Given this list of marker genes HMGB3P30, SF3B2, PTPN2, KRT7, ATP2B4, BIRC2, FOXB1, TRBC1, TCL1A, GCC1 (GRIP and coiled-coil domain containing 1), ZNF177 (zinc finger protein 177), WDR33, VAV3, PMS2P2, TRANK1, TUG1, CTDSP2, KDM7A, TMEM80, PTPRC, TRAPPC2, ING3, NAA38, NDRG1, CASP4 (NCBI Gene Id 837), RPS6, BACH1, PADI1, CDHR1, CNTRL, S100P, PITX3, ADAR, HEXIM1, MAP1LC3B, SULT1B1, USP15, GABPB1-IT1, MAPK14, THAP11, REPS2, TLL2, TUBD1, PHF1 (PHD finger protein 1), HBZ (hemoglobin subunit zeta), SHCBP1L, GPR171, PARP8, VEGFC, PELI1, FRY, CEACAM1, SIRPG, ARGLU1, CTNNBL1, SFI1, SMURF1, AGTPBP1 (ATP/GTP binding carboxypeptidase 1), PRKAG2, CD40LG, DPEP2, RPL17, RPL35A, ZNF586, CD55, ELAVL3, PDE6G, PRKAB1, LTB, STK26, RESF1, LAX1, ZNF44, BCOR, ZDHHC4, PRR14, CCDC59 (coiled-coil domain containing 59), AKAP8, ATXN7L3B, C2orf68, UBE2D2, SAMD9, RNF139, PDLIM3, CDH2, STAR, MANF, NME8, NCBP3, SLC10A3, VILL, C1RL, CX3CR1, RSRP1, IPCEF1, SYCP2, LSM14A, CRYBB3, CHPT1, ISG20, MUTYH, PMAIP1, RPL5, MAF, H1-0, PCDHGB5, OR2J2, CDK5RAP3, RYK, NPRL2, FLT3, RFX5, UBIAD1, CCNT2, HSPA1L, SMPD3, DICER1, KIF21B, EIF1, BBS4, SFXN1, MTNAP1, THAP4, C10orf95, RBM5, ITK, VCL (vinculin), TARP, SMG7, RUFY1, AKAP17A, HRH3, TMEM131L, MARCHF8, TMSB15B, ADGRG1, SPOP, EXTL1, FAM124B, ANAPC5, CEP63, RETREG3, APOBEC3G, PHTF2, FAM136A, CDK7, FBXL5, PPP1R16B, RNF41, EXT1, SRSF3, NACA, RPL12, SPSB3, SLC25A14, ADGRD2, EIF2AK1, CKLF, TRAF4, ODF2, ASTE1, CACNA1E, EIF1AY, JARID2, MIA3, NFIB (nuclear factor I B), COQ8A, SRP54, MYB, NPEPL1, CZIB, LHX1, GDPD5, AQR, WDR6, CUTC, MTERF1, LINC01565, OSER1, HTR7, GALT (galactose-1-phosphate uridylyltransferase), GAB1, NCF4 (NCBI Gene Id 4689), GZMA, RAB33A, RIC3, ZSCAN16, SMC4, TRADD, CRYBB1, LONP2, KDM6A, SH2D1A, PLCB1, ETS2, FAM186A, RPS11, SMIM27, here is a description of the gene set: In the present study we used Affymetrix oligonucleotide microarrays to produce gene transcription profiles for the major leukocyte types in humans. This comprehensive dataset enabled us to not only establish which genes were expressed in each leukocyte type, but also which genes were expressed in each subset after activation. The used of a comprehensive dataset of gene profiles from all the major human leukocyte subsets enabled a novel and powerful means for identification of genes associated with single leukocyte subsets, or different immune paradigms. Human Gene Set: GSE3982_MAC_VS_BASOPHIL_DN studied in species Homo sapiens from publication Jeffrey KL, Brummer T, Rolph MS, Liu SM, Callejas NA, Grumont RJ, Gillieron C, Mackay F, Grey S, Camps M, Rommel C, Gerondakis SD, Mackay CR (PMID 16474395) Genes down-regulated in comparison of macrophages versus basophils.